The following is a description of a gene set: Genes predicted to be targets of miRBase v22 microRNA hsa-miR-5696 in miRDB v6.0 with MirTarget v4 prediction scores > 80 (high confidence targets). from publication Chen Y, Wang X (PMID 31504780) Human Gene Set: MIR5696 species: Homo sapiens, and this is the list of marker genes: PNPLA8, PRKAG1, CLIC2, ERP44, LIMD1, PPP1CC, EMC6, TMEM135, CD1B, MTRF1, OR51E2, PJA2 (NCBI Gene Id 9867), MSL2, BCL2L15 (NCBI Gene Id 440603), CAB39L, FOXN2, SCAI, MYEF2, SPTAN1, UHRF1, LPGAT1, PCM1, MBTPS2, LRRTM3, ZNF175, NUFIP1, ESR1, NSF, RSPO3, SYPL1, AASS, ELOVL6, CACUL1, MAT2B, TLR5, CT47A5, NCOA5, SNX13, HTR2A, ARMT1, KLHL5, TBC1D4, ZNF655, TTC33, ACVR2A, XKR6, TRAK1, PTGS2, ADD3, EYS, DRAM1, JRKL, DCAF10 (NCBI Gene Id 80211), ABCG2, UBE2D1, FAM76B, KIF2A, APIP, PPFIA2, NUFIP2, HOOK3 (NCBI Gene Id 84376), ELAVL4, USP7, CEP350, SH3GL3, KIF16B, DCTN5, RND3, PTGFR, CHN2, SPATA12, TOX3, MDGA2, RABGGTB, SLMAP, GSPT1, DPYD, DNAJC27, CYBB, RMDN2, IPO5, AK7, ELMOD1, TCF20, SP110, SHLD2, ZBTB49, RIMBP2, LPAR6, YES1, PREX2, TPK1, TBCA, STRBP, ARL15, TNFSF8, ZNF331, LIMA1, LRATD1, DNAJA1, VASH2, OLIG3, GATAD1, ETNK1, ITGB8, BCHE, MAPK9, WWC2, DHX58, CUL5 (NCBI Gene Id 8065), ZFP69, RPS6KA3, TMEM170B, SOX30, SGIP1, TSPAN6, CHIC1, RMND5A, NOL3, IL1RAP (NCBI Gene Id 3556), CDC73, CYB5R4, ITGA4, GLRA3, RTN1, TBL1XR1, DMGDH, GPR65, TMEM229A, ACTC1, GPR180, DYNLT5, MIER1, RWDD3, BAIAP2L1, BIRC6, KLHL6, ALKBH3 (NCBI Gene Id 221120), PLS1, USP9X, FRYL, APC, ATE1, ACSL5, MAP3K7CL (MAP3K7 C-terminal like), MOB1B, MARCHF6, TMEM35B, PDAP1, FBXL5, NECTIN3 (nectin cell adhesion molecule 3), STRIP2, PRRG1 (NCBI Gene Id 5638), SNTG1, NEMP1, B3GALNT1, GABRB2, ATXN7, PKIB, RIN2, ZNF528, ERBB4, SNX4, SNAP25, STK38L, HPCAL4, DTNA, ACIN1, EXPH5, DGKE, HTR7, GPR34, OXR1, EDA, CT47A6 (cancer/testis antigen family 47 member A6), LARS1, CHAC2, CLTC, HEY2, ZXDA, JMY, RBM41, JAZF1, UBE2Z, AFF3, PRDM10, FZD3, TMOD2 (tropomodulin 2), TCTN2, DCDC2, RC3H1, STOX2, ZNF84, DDX46 (NCBI Gene Id 9879), GNG12, KDM3A, ZNF710, ACTN2, SHC4, SCD5, CT47A8, TMEM178B, HNRNPH3, CHCHD7 (NCBI Gene Id 79145), KCNQ3, ETAA1, TP63, OMG, MYRIP, TNS3, DUSP10, SLC6A11, MAPK10, ZFHX3, CT47A4, SH3BP5 (NCBI Gene Id 9467), CT47A11, UBE4A, ARHGAP10, PHIP, DIO2, ERO1B, MRPL17, OTUD6B, BRWD3, PPIE, ZNF202, SENP6, PA2G4, PRTG, HELQ, MPZL3, ABCE1, TMTC1, ELK4, SPOPL, PIAS2, ZBTB1, GPC4, CT47A3, ADGRF1, FAR1, MOSPD2, CHAF1A, REPS1, NLGN4Y, RNF11, GIMAP1, EDNRB, KANK2, KCNMA1, SLC4A4, STAM, TCF7L2, ZNF292, CXCR2, PPP2R3A, HYCC2, PHACTR3, BTBD9, ZNF385C, UBL3, MMGT1, YTHDC2, TMEM200A, OGN, ANOS1, INTS2, WHAMM, NHSL3, CT47A1, PCDH20, AGFG1, ALDH1A2, ARFGAP3, GJA9, RHOQ, ASXL3, PLAC8, SLC5A3, CTSO, DENND4C, DOK6, CPD, HBS1L, FZD8 (frizzled class receptor 8), HSCB, MTOR, GPR155, SLC27A2, TDRD5, DCP2, TTLL7, SEC24B, FGF5, FBXW7, MFSD6, ADCYAP1, HDAC8, SNCG, DCX, GUCY1A2, ANXA2, ANO5 (NCBI Gene Id 203859), ENPP4, TDG, BTBD10, TLCD4, NUP43, KCTD12, ARHGAP35, SLC30A4, SMIM15, ENTPD7, FLI1, VPS50, TRAK2, RABGEF1, CT47A12, ZBTB10, AMD1, COL5A2, MET, KLHDC10, JADE1, COX18, TET3, RHOJ, RB1CC1, KCNJ2, KDM7A, RASGEF1B, DDT, SFI1, SANBR, ARMC2, TMEM241, CLDN8, VCAN, AFF4 (NCBI Gene Id 27125), SERINC1, GLS, NR2C1, HFM1, NRAS, IRF2, MCTP2, CDC5L, TCP11L2, SMAD5, GJA1, CPT1A, SLC10A2 (NCBI Gene Id 6555), DDX5, IL1A, NPY1R, PHF6, SEC61G, TPR, MKX, TAX1BP1, NCEH1, HFE, PRPS2, PRKAA2, CRACD, GXYLT1, NAMPT, MRPL50, ZNRF3, WDFY3, USP25, CT47A7 (cancer/testis antigen family 47 member A7), NYAP2, QKI (NCBI Gene Id 9444), EIF5A2, GABPA, CHSY3, DNAJB14, UBE2G2, ZFX, ZNF326, SDCCAG8, UGDH, PMP2, ADGRE2, HMX1, HELZ2, RAB33B, AHCTF1, MYO6, CAMTA1, POMGNT2, VAMP4, PRP4K, KRT72, WNT9B, ELL2, NUCKS1, CADPS2, GDF9, FANCF, STXBP5, GARIN2 (golgi associated RAB2 interactor family member 2), TUSC3, C2CD5 (C2 calcium dependent domain containing 5), MUC15, ZFPM2, LRP1B, FKTN, SPINK8, POLR3K, RRH, ZFAND5, RTKN2, ZNF430, ADARB2, RFX3, SLC25A16, GNAI3, SLC24A2, PLEKHH2, MEGF11, SORBS2, ADAMTS5, DBT, SLC6A1, MBNL3, PPM1L, RAB30, TMF1, MLPH, MEP1A, HUWE1, UBE3C, GPHN, YTHDC1, CD163L1, DSC3, DCUN1D5, DPH7, GPR84, NKTR, TATDN3, ITFG1, TMX4, CT47A10, DHRS12, NDFIP2, FUT2, ARHGAP21, RNFT1, UBR5, MAGEE1, CPPED1, PIK3CA, GPBP1, PAIP1, VAMP7, B3GNT5, ADGRB3 (adhesion G protein-coupled receptor B3), LRRTM2, CRISPLD1, LSM11, MTAP, SORBS1, TEAD1, DDX60L, NEXMIF, CALCRL, F13B, KIAA0408, MINPP1, LZTR1, OPRM1, PHACTR2, RANBP3L, UBASH3B, OGT, RGS5, SGCB, LYSMD3, PDE3A, NTAQ1, ILRUN, FBXO21, FAM83B, GRIK2, CCDC82, WNT2, CUL4B, CXXC4, NET1, SSR3, DNAI2, IGSF10, DAB2, LANCL3, SLC25A24, THSD7A, NOP14, GNAS, TDP2, CALHM4 (calcium homeostasis modulator family member 4), KRBOX4, MAP4K5, NAALADL2 (NCBI Gene Id 254827), TFEC, EDN1, ERO1A, UHRF2, IRX1, TMCO3, HDX, CADM2, CTDSPL, UCHL5 (NCBI Gene Id 82736), PGM2L1, ANKRD28, PHKB, AFF2, RPS6KA6, MAB21L1, NDUFA5, CREB1, TDRP, SDK2, HACD1, FUBP1, PDP1, EIF2A, OVOL2, LSAMP, IQGAP2, PTBP2, TENT5A, FSD1L, ANKRD36B, PRKAR1A, KCNH8, SREK1IP1, C5orf47, FBXO32, GLYATL2, CCSER2, MED13L, EPB41L5, SPIRE1, ZFP14, GRK5, ZIC3, SERPINB10, ONECUT2, IGHMBP2, JAG2, FRMPD4, NAPEPLD, DGKH (NCBI Gene Id 8524), UBE2D3, SKI, BRME1, SYNJ2, SOBP, SLC25A26, TMEM38B, CLEC12B, SECISBP2L, HOXB7, CAMK2D, CT47A9, RUFY2, THRAP3, ITGBL1, ATP1B1, NAP1L1, LIN54, FAM131B, GSKIP, ANKRD44, TMEM45A, NLN, DEPDC1, STK26, SLC9A2, PTCHD4, SCUBE3, KAT2B (lysine acetyltransferase 2B), MARF1, SNX2 (NCBI Gene Id 6643), OGFRL1, BACH2, EPHA3, MOB3B, IL6ST, GLIS3, SEM1, SCN11A, USP49, GLIPR1L2, KIF5B, KLHL11, ELP4, GRIA2, MTDH, CTBS, TMX3, CNGA3, TRUB1, ZMAT3, RAB3B, TMEM169, SSPN, NEK7, RNF212, TMEM62, LCP1, ADCY7, HIPK1, CD180, SNTB2, SMARCA5 (SWI/SNF related, matrix associated, actin dependent regulator of chromatin, subfamily a, member 5), SFMBT2, SMIM14, ELN, PRDX6, HCN1, LETM1, ELAPOR2, ST6GAL2, IRS1, CDV3, ZNF704, ZNF532, SPEF2 (sperm flagellar 2), PKN2, EEF1A1, PRPF38B, NTS, FRS2, CT47A2, USP38, ROBO2, MAP3K7, LRP6, AKTIP, RPRD1B, NCKAP5, LIMS1, CHURC1, CYLD, UGT2B4 (NCBI Gene Id 7363), MARCHF7, TRIM2, BRCC3, GYS2, CBFA2T2, NOVA1, NCOA7, MTERF3, TCEANC, CACNB4, HIPK3, MIS18A, PRRC1, NRXN3, TRIM37, SQLE, IPO7, TPP2, RBM20, IDNK, KIF21A, SLC35G1 (NCBI Gene Id 159371), RBFOX1, SLC38A1, IMPACT, C6orf62, CEP126, ATP8A1, IGSF11, ING1, TMEM220, MARK1, MMRN1 (NCBI Gene Id 22915), SULT6B1, ELAVL1, CA2, B4GALT7, FAM210A, C1D, FAT3, FBXW2, TCF4, ZNF519, ABHD13, LILRB5, GASK1B, MS4A2, PCNP, MOXD1, POC1B, GLT6D1, FOXA1, PAPOLG